The following is a description of a gene set: Mouse Gene Set: GOBP_MODIFIED_AMINO_ACID_TRANSPORT studied in species Mus musculus The directed movement of modified amino acids into, out of or within a cell, or between cells, by means of some agent such as a transporter or pore., and this is the list of marker genes: Slc46a1, Slc7a11, Pdpn, Slc25a32, Slc22a8, Slc25a20, Slc6a12, Ctns, Folr2, Slc1a4, Slc22a16, Slc25a40, Slc7a6, Slc13a3, Slc22a5, Lrp2, Slc22a15, Nherf1, Slc16a12, Slc22a4, Abcc5, Gja1, Slc5a6, Slc22a21, Slc6a13, Slc6a14 (NCBI Gene Id 80646), Abcc2, Slc7a9, Slc6a8 (solute carrier family 6 (neurotransmitter transporter, creatine), member 8), Slc3a1, Slc19a3, Mgst1, Slc38a2, Slc6a20a, Slc25a29, Abcc4, Slc7a13, Abcc1, Slc16a9, Slc22a1, Slc25a39, Folr1, Slc19a1